The following is a description of a gene set: from publication Chen Y, Wang X (PMID 31504780) Genes predicted to be targets of miRBase v22 microRNA hsa-miR-4676-5p in miRDB v6.0 with MirTarget v4 prediction scores > 80 (high confidence targets). Human Gene Set: MIR4676_5P species: Homo sapiens, and this is the list of marker genes: AKAP13, FBXW11, ANKRD23, CEP85L, FANCC, CHD9, ST7L, DCUN1D4, USP49, ABCD3, CSNK1G3, ZNF142, EPB41L5, CADM2, OSMR (NCBI Gene Id 9180), PCDH19, SBNO1, ZNF398, MEF2C, CXXC5, DOCK5, RIPK4, MBD4, CHSY3, RBBP5, ELOVL6, GUCY2C, LSM12, EPOR, CAPN7, ELAVL4, NDEL1, CEP128, YPEL5, PLPPR4, SNRPD3, WEE1, ANKRD61, ZNF827, DENND5A, DIPK2A, WNK3 (WNK lysine deficient protein kinase 3), DYNC1LI2, WDFY3, EXT1, TPT1, ZNF425, DPP8 (NCBI Gene Id 54878), ANK3, TSSK1B, ITGA2, PURA, ZNF516, STOX1, POLR3B